Given this list of marker genes Slco2a1, Slco1b2, Abcc3, Abcc4, Slco2b1, Slc22a8, Slc27a1, Slc22a1, Slc22a2, Slco3a1 (NCBI Gene Id 97427), Slc22a6, Slc22a7, Slco4a1, here is a description of the gene set: species: Mus musculus Mouse Gene Set: GOMF_ICOSANOID_TRANSMEMBRANE_TRANSPORTER_ACTIVITY Enables the transfer of icosanoids from one side of a membrane to the other.